The following is a description of a gene set: species: Homo sapiens from publication Fu W, Ergun A, Lu T, Hill JA, Haxhinasto S, Fassett MS, Gazit R, Adoro S, Glimcher L, Chan S, Kastner P, Rossi D, Collins JJ, Mathis D, Benoist C (PMID 22961053) Human Gene Set: GSE40273_GATA1_KO_VS_WT_TREG_DN Genes down-regulated in T reg: GATA1 knockout versus wildtype. The transcription factor FoxP3 partakes dominantly in the specification and function of FoxP3+ CD4+ T regulatory cells (Tregs), but is neither strictly necessary nor sufficient to determine the characteristic Treg transcriptional signature. Computational network inference and experimental testing assessed the contribution of several other transcription factors (TFs). Enforced expression of Helios or Xbp1 elicited specific signatures, but Eos, Irf4, Satb1, Lef1 and Gata1 elicited exactly the same outcome, synergizing with FoxP3 to activate most of the Treg signature, including key TFs, and enhancing FoxP3 occupancy at its genomic targets. Conversely, the Treg signature was robust to inactivation of any single cofactor. A redundant genetic switch thus locks-in the Treg phenotype, a model which accounts for several aspects of Treg physiology, differentiation and stability., and this is the list of marker genes: KCNK13, HIF1A, WDFY1, HLA-DMA, PIGP, LPCAT1, TASOR, MAP7, RASSF5, ZNF639, ZMYM4, RETREG1, KCTD18, SCAPER, MAP3K1, ITPK1, RHOF, GPR183, TBC1D5, VASP, PLEC, ZNF217, SYK, TMEM63A, PLEK, CHSY1, GIMAP4, DPP4, CARD6, SPATA6, CD200, ACTG1, ANKRD11, SNX8, PTPN1, NUDT15, SP4, FLNA, NFATC2, VOPP1, MAP3K8, PURA, SCAI (suppressor of cancer cell invasion), KMT2C (lysine methyltransferase 2C), KYNU, SUN2, DIPK1A, LPP, DENND4B, LNX2, CYTH1, SNAPIN, PLXNC1, MAP4K2, ARHGEF18, PARP8, PROSER1, IL6R, CYBC1, GRAMD4, BEND5 (BEN domain containing 5), NCF1, PRRC2C, JAK1, AKAP12, ARID5B, TMEM229B, ZNF157, VCF1, ZNF287, SFI1, PTPN6, APOE (apolipoprotein E), MEF2C, HES1, RAB31, MALT1, PNPLA7, NCOA3, SLC25A37, DCUN1D1, CREB1, LY6D, ACAP2, IFT140, AHR, TEP1, SPTAN1, ZNF493, KLHL26, ZBTB18, RUFY2, TLR7, IRF3, ZEB1, DOCK11, C3orf33, ITPR2, FBXO34, GIMAP8, VPS41, C5orf34, SNX10, LRCH1, MED12, HLA-DMB, HOPX, SYNJ2BP, COLCA1, IL27RA (NCBI Gene Id 9466), PHLPP1, THUMPD3, CCDC93, NCOA1, PACS1, CIITA, BMP2K (BMP2 inducible kinase), PRR14, MRM1, ING5, CYP4F3 (cytochrome P450 family 4 subfamily F member 3), SFXN4, GPR18, SESN3, SLAMF1, FUT11, CCDC28A, MGA, PHC2, MICALL1, TRIM7, MBIP (NCBI Gene Id 51562), NR2C1, IRAK4, BIRC3, LLGL1, EPC1, NSMCE1, KDM2B, CALHM2, HNRNPH3, ZNF841, ADD3 (adducin 3), ZSCAN26 (NCBI Gene Id 7741), MAST3, NCF2, CRTC3, BACH2, FILIP1L, CCDC122, ABHD6, DENND2D (DENN domain containing 2D), PSEN2, ZFP36L1, TIGD2, HSH2D, STX16, POLD1, ANKFY1, OGFRL1, MAP4K3, SETD6 (NCBI Gene Id 79918), PFKFB4, CARD11, P2RX4, PARP3, BTBD8, CISD2, STX7, SMPDL3A, PDLIM1, ZDHHC23, CHD2, CLCF1, RALGPS2, CFAP97, LIPC, ANKH, TRNAU1AP, CTU2, ATE1, PLBD1, DENND11, USP25, HDAC1, FAM53B, IFNGR2, ERMARD, RELB, CREBRF, ITPR1, SLC2A3, GPSM1, UBE2R2, KMO, ARHGAP17, CBLB, CCR7, SYNE1, TMEM268